Given this list of marker genes TGFB1, AGTR2, NR3C2, AGT, ACE, MAS1, AGTR1, CTSG, CYP11B2, REN, BDKRB1, BDKRB2, ACE2, KNG1, ATP6AP2, CMA1, NOS3, here is a description of the gene set: studied in species Homo sapiens ACE inhibitor pathway Human Gene Set: WP_ACE_INHIBITOR_PATHWAY